The following is a description of a gene set: Any process that an organism uses to control its balance, the orientation of the organism (or the head of the organism) in relation to the source of gravity. In humans and animals, balance is perceived through visual cues, the labyrinth system of the inner ears and information from skin pressure receptors and muscle and joint receptors. species: Mus musculus Mouse Gene Set: GOBP_NEUROMUSCULAR_PROCESS_CONTROLLING_BALANCE, and this is the list of marker genes: Bcr, Shank3, Psap, Camk2b, Aplp2, Abr, Rbfox2, Ei24, Pou4f1, Ptprq, Neurog1, Camta1, Jph4, Tnr, Ankfn1, Ush1g, Clrn1, Cntnap1, Jph3, Myh10, Hexa, Nlgn2, Ush1c, Pde8b, Iglon5, Gpr88, Pcdh15 (protocadherin 15), Sox2, Abl1, Pou4f3, Nefl, Nr4a3, Pou4f2, Dlg4, Hexb, Rbfox1, Foxs1, Ap1s2, Gigyf2, Herc1, Pafah1b1, Tifab, Rac3, Slc1a3, Shank1, Zfp212, Elp6, Cacna1a, Kcnma1, Nrxn1, Nkx6-2, Cwh43, Cln8, Rubie, Igdcc3, Myo7a, Atp1a3, Nbn, Clic5, Aldh1a3, Vps13a, Myo5a, Tpp1 (NCBI Gene Id 12751), Gaa, Adcy5, App, Gm2a, Hmx3, Rest, Atp2b2, Aars1, Abl2, Bloc1s4, Cdh23, Grin2c (glutamate receptor, ionotropic, NMDA2C (epsilon 3)), Cln3